The following is a description of a gene set: studied in species Homo sapiens Transcription regulation during the cell cycle is crucial for ensuring genes are expressed at the right time and in the correct amounts, coordinating key processes like DNA replication, mitosis, and cell division. In our study, Human Gene Set: PULVER_FOREY_CELLCYCLE_ENRICHED_TFS_S2 Transcription factors and DNA binding proteins enriched at promoters of genes whose expression fluctuates during the cell cycle (pVal < 0.05) and peak in the second half of the S phase (S2) in K562, and this is the list of marker genes: FOS, ELK1, PTBP1, MLX, RBFOX2, FOXP4, ZFX, MXD1 (NCBI Gene Id 4084), ZFP64, ARID3A (NCBI Gene Id 1820), SMARCE1, MEF2D, IKZF1, TAF1, NR2C2, KLF13, ZNF574, ZNF350, CREM, JUNB, KDM4B, ZSCAN22, EGR1, SMAD3, GATA2, ZNF311, ZNF766, RFX5, NFXL1, USF2, AFF1 (ALF transcription elongation factor 1), BHLHE40, CXXC5, SAFB, MNT, CHD1, PHF20, E2F3, TBL1XR1, NR4A1, ZBTB17, ETV6, ZBTB12, DPF2, SNRNP70, JUN, ZC3H11A, ZNF384, ZNF382, HDAC8, ZNF644, ZHX1, SIRT6, GATA1, NSD2, BRD4, IRF1, GTF2A2, EGR2, UBTF, CHD7, BCLAF1, FOXK2, HDAC1, ZBTB26, TAF15, SIN3A, KHSRP, POLR2G, MITF, ARNT, SRF, ATF3, ZNF511, MXI1, DMBX1, FOSL1, NRF1, NR2C1, CEBPG, HMG20A, ZNF740, MTA3, ZNF318, DEAF1, HDGF, ELF1, MAFK, VEZF1, ADNP, MYBL2, YY1, TFDP1, SP1, ESRRA, NCOR1, KAT2B, SMC3, E2F5, MAFG, TBPL1, HBP1, ZNF41 (zinc finger protein 41), SUPT5H (NCBI Gene Id 6829), TFAP4, ETS1, RFX1, NONO, HMGXB4, KLF16, KDM5B, TOE1, SMAD1, NR2F2, PHF21A, CREB1, SRSF7, CTCFL, DDX20, GATAD2B, TBX18, ZSCAN29, ATF2, SIX5 (SIX homeobox 5), SIN3B, ZKSCAN1, GABPA, ZBTB11, ASH1L, ATF6, FOXA3, ZNF583, DMTF1, MBD2, ETV1, GTF2F1, RBM15, KLF15, SOX6, CDC5L, RBBP5, CGGBP1, HNRNPUL1, HSF4, FOXO4, PCBP2, PATZ1, ARID1B, ZNF79, RBM4, HCFC1, ZNF316, E2F6, BACH1, SP2, RUNX1, RLF, ZNF639, STAT6, ZNF528, TFCP2, ZBTB1, HNRNPH1, SMARCA4, ETV5, CBX3, NR1H2 (nuclear receptor subfamily 1 group H member 2), USF1, ATF4, CREB3, POLR2H, ZBTB2 (zinc finger and BTB domain containing 2), RBM22, DIDO1, ZC3H8, SMARCC2, ZNF830, ZNF143, CBFA2T2, FOXK1, NKRF, ZNF584, STAT5A, HES1, ELF4, ZNF7, TCF7L2, RBM34, ZNF449, ZNF202, MYC, TRIM24, HNRNPL, E2F4, ZNF184, IRF2, SREBF1, ZNF197, HMGN3, TBP, GTF2E2, ZNF395, SAP30, CC2D1A, PRDM10, NFIC, LCOR, FIP1L1, ZNF76, ZNF83, RBM39, NFATC3, NCOA1, GTF2B, ZNF12, AFF4, FEZF1, TEAD4, TRIM28, GTF2I, ZNF700, LARP7, MEIS2, RAD51, HLTF, ID3, PHF8, E4F1, NCOA2, ZNF84, EP400, HMBOX1 (homeobox containing 1), ZNF431, CSDE1, BRD9, TARDBP, EP300 (E1A binding protein p300, NCBI Gene Id 2033), RCOR1, RBM25, CTBP1, MLLT1, E2F7, AGO1, ZNF281, TAF7, ATF1, CBX1, BCOR, ZNF589, ZBTB33, ZNF3, XRCC5, ZNF317 (NCBI Gene Id 93652), PRPF4, MEF2A, ZMIZ1, ZBTB7A, SETDB1, SKIL, ZNF282, RREB1, MGA, TAF9B, CEBPB, CUX1, ARHGAP35, ZNF764, GATAD2A, E2F1, CBFA2T3, ATF7, KLF1, SMAD4, ZBTB14, MYNN, CHCHD3, REST, NEUROD1 (NCBI Gene Id 7853), NFE2, HDAC3, ZNF592, FOXM1, ZZZ3, CBFB, HNRNPLL, ZBTB5, CCNT2, OTX1, MTA2, HDAC2, NBN, ZNF626, KAT7, L3MBTL2, PHB1, TRIM25, EGR3, ZEB2, SMAD5, ZC3H4, ZBTB9, PCBP1, LEF1, GABPB1, KDM1A, PML, RNF2, MTA1, NFRKB, TCF7 (NCBI Gene Id 6932), NR2F1, SPI1, ZNF609, ZNF121, DACH1 (dachshund family transcription factor 1), MAZ, THRB, EMSY, MAX, THAP12, ZNF175, ZBTB40, JUND, TAL1, PKNOX1, FUS, HNRNPK, NFYB, ZNF274, ARID4B, CHD2, ZNF263, ZFP91, NFYA, TEAD1, E2F8, ZNF148, THAP1, SRSF1, CEBPZ, MAFF, ZKSCAN8, SRSF3, ZSCAN32, ZNF24, TCF12, ZNF215, POLR2A, GMEB1 (glucocorticoid modulatory element binding protein 1), RELA, ZNF239, CREB3L1, U2AF1, FOXJ2, TCF3, CTCF, FOXP1, ZBED1, RB1, KLF6, ERF, POLR2B, GTF3C2 (general transcription factor IIIC subunit 2)